Given this list of marker genes HAL, SDSL, SDS, FTCD, SRR, here is a description of the gene set: species: Homo sapiens Human Gene Set: GOMF_AMMONIA_LYASE_ACTIVITY Catalysis of the release of ammonia by the cleavage of a carbon-nitrogen bond or the reverse reaction with ammonia as a substrate.